The following is a description of a gene set: Mouse Gene Set: REACTOME_NADE_MODULATES_DEATH_SIGNALLING NADE modulates death signalling species: Mus musculus, and this is the list of marker genes: Casp2, Ngfr, Ngf, Casp3, Bex3, Ywhae